Given this list of marker genes TOR1AIP2, GUCA2A, DCAKD, AZIN1, GADD45G, PRKN, PEX14, ABCG1, LGALS3BP, HIBADH, SELENOP, SDHAF2, WBP1, YPEL5, RAB40B, UBE2D3, PSMD8, ARHGEF1, ARC, CDR2, NR1D1, SPATA6 (NCBI Gene Id 54558), CDK18, SMIM14, CBS, C1QTNF4, PEA15, PNPLA2, FXR2, ACO2, NT5C3A, SMPD1, SMNDC1, ORMDL3, ANKRD33B, MGAT4B, IL12A, MAPK9, FMO3, SCRIB (NCBI Gene Id 23513), CTH, CPSF7, TCIM, ATP6V0A1, GCNT2, CD68, MYL9, SLC10A6, PPARA, CYP2F1, ARL4C, ZFP37, TAF12, UQCRFS1, SCARB1, ATP12A, SRFBP1, STXBP4, GADD45A, ARRDC4, ME1, BATF (basic leucine zipper ATF-like transcription factor), RCHY1, AGT, ST3GAL1, FYCO1, FNDC10, NBL1, SELENBP1, MTSS1, CADM3, BAG4, PLEKHH3, RPP40 (NCBI Gene Id 10799), CYP27B1, RBP4, ATF3, FOXC2, CERS4, TBC1D15, PLOD1, HOXB6, NAMPT (nicotinamide phosphoribosyltransferase), HTATIP2, RSRP1, ACTRT2, MSMO1, ADIPOQ, SLC26A7, FDPS, OIT3, MMP3, GADD45B, DHX40, GOSR1, PARD6B, CFD, GSTT2, ABHD5, VPS37C, FOXK1, PITPNB, ADAMTSL4, SERPINE2, LTC4S, SLC48A1, UBE2G2, SRPRB, RGL1, CCDC92, COL13A1, MLX, TTC36, ADGRG3, EIF2D, TMEM106B, NR4A1, ODC1, PRKAG2, FNBP4, MDFI, SGCD, HMOX1, S100A3, TXNIP, RIOK3, RAB3B, FKBP1A, ARPC1A (actin related protein 2/3 complex subunit 1A), DNTT, NAAA, LMAN2, MRPL10, S100A8, LACTB2, TXN2, TP53I13, CDK20, CARD19, HSPA8, UBD, MEMO1, LMF1, KCNQ5, GLRX, COL18A1, RNF144A, MRM2, PITHD1, TCN2, SC5D, TGIF1, THOC2, PRRC1, SLC2A9, WDR45B, HSD3B7, EPHX1, MMD2, ASNSD1, TNFRSF1A, PAH, ATP6V1A, TELO2, PARP6, RARRES2, OLFML2B (NCBI Gene Id 25903), ATL3, OCIAD1 (NCBI Gene Id 54940), ZC3HC1, TPRG1L, TLCD4, CARTPT, EIF2B2, PC, RACK1, SGTB, TALDO1, SLC26A3, MYO5A, RAPSN, NRL, SNX5, STAT4, RBMS2, RIMOC1, IKZF2, DUSP1, TGFBI, RNF19B, CYP2D6, CDK2AP2, PVT1, SAPCD1, CCNG1, LRRK1, RYBP, BCAT2, CD36, here is a description of the gene set: species: Homo sapiens Human Gene Set: GSE4748_CTRL_VS_LPS_STIM_DC_3H_DN Genes down-regulated in monocyte-derived dendritic cells: untreated versus LPS (3h). from publication Macagno A, Molteni M, Rinaldi A, Bertoni F, Lanzavecchia A, Rossetti C, Sallusto F (PMID 16717116) A cyanobacterial LPS antagonist prevents endotoxin shock and blocks sustained TLR4 stimulation required for cytokine expression. We report the identification and biologic characterization of an LPS-like molecule extracted from the cyanobacterium Oscillatoria Planktothrix FP1 (CyP).